Given this list of marker genes Akr1c6, Akr1c21, Akr1c14, Akr1c20, Akr1cl, here is a description of the gene set: studied in species Mus musculus Mouse Gene Set: GOMF_ANDROSTERONE_DEHYDROGENASE_B_SPECIFIC_ACTIVITY Catalysis of the reaction: NAD(P)+ + androsterone = NAD(P)H + H+ + 5-alpha-androstane-3,17-dione. The reaction is B-specific (i.e. the pro-S hydrogen is transferred from the 4-position of reduced nicotinamide cofactor) with respect to NAD(P)+.